Given this list of marker genes ABLIM3, PDLIM5, DKK1, CLDN1, B4GALT4, TIMM44, PGBD5, CDKN1C, KRT6B, BLZF1, PHLDA3, PHLDA2, FBXL18, GABPB1, KRT6A, PRSS8, TGM1, TM4SF1, CLTB, SERPINB2, PCDH7, ALDH1A3, TJP1, CDC42EP1, ADRB2, SERPINE1, NECTIN2, BCL2L1, ANGPTL4, MAP3K11 (mitogen-activated protein kinase kinase kinase 11), DSG3, EMP1, TNFRSF21, LRRC8B, GBP1, PKP2, EHD4, ITGA2, GRAMD2B, THBS1, MRPL33, OCLNP1, GLIPR1, AKAP12, ITGB6, FST, TLR2 (toll like receptor 2), ARHGEF3, B3GNT2, CD24P4, EZR, TGFA, PRKAG2, CDH1, ITGA5, TGFB1I1, HERPUD1, here is a description of the gene set: Genes whose expression peaked at 240 min after stimulation of MCF10A cells with serum. Signaling pathways invoke interplays between forward signaling and feedback to drive robust cellular response. In this study, we address the dynamics of growth factor signaling through profiling of protein phosphorylation and gene expression, demonstrating the presence of a kinetically defined cluster of delayed early genes that function to attenuate the early events of growth factor signaling. Using epidermal growth factor receptor signaling as the major model system and concentrating on regulation of transcription and mRNA stability, we demonstrate that a number of genes within the delayed early gene cluster function as feedback regulators of immediate early genes. Consistent with their role in negative regulation of cell signaling, genes within this cluster are downregulated in diverse tumor types, in correlation with clinical outcome. More generally, our study proposes a mechanistic description of the cellular response to growth factors by defining architectural motifs that underlie the function of signaling networks. from publication Amit I, Citri A, Shay T, Lu Y, Katz M, Zhang F, Tarcic G, Siwak D, Lahad J, Jacob-Hirsch J, Amariglio N, Vaisman N, Segal E, Rechavi G, Alon U, Mills GB, Domany E, Yarden Y (PMID 17322878) Human Gene Set: AMIT_SERUM_RESPONSE_240_MCF10A studied in species Homo sapiens